Given this list of marker genes LPIN1, PHKA1, PYGM, CRPPA, FKRP, MT-CO3, PGK1, ACADVL, OBSCN, LDHA, PFKM, MT-CO1, here is a description of the gene set: Human Gene Set: HP_EXERCISE_INDUCED_MYOGLOBINURIA Exercise-induced myoglobinuria species: Homo sapiens Presence of myoglobin in the urine following exercise.